The following is a description of a gene set: Catalysis of the reaction: all-trans-retinol + NADP+ = all-trans-retinal + NADPH + H+. studied in species Mus musculus Mouse Gene Set: GOMF_ALL_TRANS_RETINOL_DEHYDROGENASE_NADPPLUS_ACTIVITY, and this is the list of marker genes: Rdh12, Dhrs7, Rdh11, Dhrs7l, Rdh13, Akr1b1, Akr1b7, Dhrs3, Rdh14, Rdh10, Akr1b10, Dhrs4, Akr1b8